The following is a description of a gene set: Genes predicted to be targets of miRBase v22 microRNA hsa-miR-2682-3p in miRDB v6.0 with MirTarget v4 prediction scores > 80 (high confidence targets). species: Homo sapiens Human Gene Set: MIR2682_3P from publication Chen Y, Wang X (PMID 31504780), and this is the list of marker genes: SLITRK4, SLC30A10, TNFSF11, PNPLA4, RAD54L2 (RAD54 like 2), ANXA5 (annexin A5), KLHDC8A, RGS6 (NCBI Gene Id 9628), HAPSTR2, FUT11, COBLL1 (cordon-bleu WH2 repeat protein like 1), ATG14, ANK3, MON2, VCF1, RHOXF1, PRKCA, DPY30, CDH8, RAP1A, DCAF5, C5orf63, TMX2, DMRT2, ASIC4 (NCBI Gene Id 55515), TRAK2, MYRIP, BSN, CCDC115, ANKH, CD2AP, TOP1 (NCBI Gene Id 7150), KPNA3, ATP6V1F, NUFIP2, CCL4L2, MAGI1, SLC24A2, LINGO2, KLHL29, TIA1, DCUN1D4 (NCBI Gene Id 23142), ADRA1A, KIR3DL3, EFNA5, TMEM215, ST8SIA3, SPRY2, KCNA6 (NCBI Gene Id 3742), CDK14, RBM39, MRC2 (mannose receptor C-type 2), CXCR6, AS3MT, SLC26A7, KCNK2, PALM2AKAP2, BRWD1, COL12A1, SEL1L, DIPK1A, FAT3, NIPA1, EXOC6B, WDR1, RMND5A, EMX2, BRF2